The following is a description of a gene set: studied in species Homo sapiens Any process that modulates the frequency, rate or extent of skeletal muscle acetylcholine-gated channel clustering. Human Gene Set: GOBP_REGULATION_OF_SKELETAL_MUSCLE_ACETYLCHOLINE_GATED_CHANNEL_CLUSTERING, and this is the list of marker genes: FARP1, DOK7, CRKL, CRK, FZD9, LRP4, MESD, RAC1, FNTA